The following is a description of a gene set: Any process that modulates the frequency, rate or extent of intestinal absorption. species: Homo sapiens Human Gene Set: GOBP_REGULATION_OF_INTESTINAL_ABSORPTION, and this is the list of marker genes: APOA2, ENPP7 (NCBI Gene Id 339221), CLDN2, EPB41, HAMP, ABCG8 (ATP binding cassette subfamily G member 8), PRAP1, ABCB1, ABCG5, APOA1, LPCAT3, LEP, CYP8B1, CLDN15, APOA4